The following is a description of a gene set: electronically inferred by orthology from the curated human pathway part of: PIP3 activates AKT signaling species: Mus musculus This event has been computationally inferred from an event that has been demonstrated in another species.<p>The inference is based on the homology mapping from PANTHER. Briefly, reactions for which all involved PhysicalEntities (in input, output and catalyst) have a mapped orthologue/paralogue (for complexes at least 75% of components must have a mapping) are inferred to the other species. Reactome Pathway: Negative regulation of the PI3K/AKT network, and this is the list of marker genes: Pik3r2, Cd28 (CD28 antigen), Ppp2r5d, Fgf23, Phlpp2, Il1rl1, Fgf20, Fgf17, Klb, Kitl, Pip4k2c, Gab1, Fgf22, Erbb2, Btc, Ins2, Strn, Pdgfa, Vav1, Bdnf, Rac2, Irs1, Ntf5, Pip5k1a, Fgfr1 (fibroblast growth factor receptor 1), Irak1 (interleukin-1 receptor-associated kinase 1), Fgf8 (fibroblast growth factor 8), Fgf5, Mapk3, Hgf, Fgf7, Fgf2, Myd88, Grb2, Pik3r5, Pik3ap1, Lck, Fgf10, Esr1, Esr2, Nrg3, Fgf1 (fibroblast growth factor 1), Il33, Cd80, Ppp2r5a, Pip5k1c, Ppp2r1b, Fgf15, Egfr, Kl, Ins1, Pik3cb, Fgf6, Areg, Frs2, Kit, Them4, Epgn, Fgf16, Ier3, Irs2, Flt3l, Erbb4, Pdgfb, Pdgfrb, Fgf4, Ppp2r5b (protein phosphatase 2, regulatory subunit B', beta), Phlpp1, Trat1, Icos, Cd19, Fyn, Tgfa